The following is a description of a gene set: Spermatogenesis maturation arrest Maturation arrest (MA) is defined as germ cells that fail to complete maturation. Uniform MA is characterized by spermatogenic arrest at the same stage of spermatogenesis throughout the seminiferous tubules. MA is subcategorized into early MA, in which only spermatogonia or spermatocytes are found, and late MA, in which spermatids are detected without spermatozoa. species: Homo sapiens Human Gene Set: HP_SPERMATOGENESIS_MATURATION_ARREST, and this is the list of marker genes: TEX11, MSH5, M1AP, TEX15 (NCBI Gene Id 56154), XRCC2, SHOC1, MOV10L1, KASH5, ZMYND15, PNLDC1, TERB1, TERB2, TDRD9, STAG3, SPATA22, SYCE1, RNF212